Given this list of marker genes COPS8, DDB2, ACTL6A, CUL4A, NFRKB, PARP2, INO80B, RAD23B, PARP1, COPS4, COPS3, MCRS1 (microspherule protein 1), XPC, COPS7A, DDB1, RBX1, RPS27A, COPS6, COPS2, ACTB, UBA52, INO80C, COPS5, CUL4B, INO80D, RAD23A, GPS1, COPS7B (NCBI Gene Id 64708), INO80E, YY1, INO80, ACTR8, RUVBL1, UBB, CETN2, ACTR5, UBC (NCBI Gene Id 7316), TFPT, here is a description of the gene set: part of: Global Genome Nucleotide Excision Repair (GG-NER) Reactome Pathway: DNA Damage Recognition in GG-NER species: Homo sapiens In global genome nucleotide excision repair (GG-NER), the DNA damage is recognized by two protein complexes. The first complex consists of XPC, RAD23A or RAD23B, and CETN2. This complex probes the DNA helix and recognizes damage that disrupts normal Watson-Crick base pairing, which results in binding of the XPC:RAD23:CETN2 complex to the undamaged DNA strand. The second complex is a ubiquitin ligase UV-DDB that consists of DDB2, DDB1, CUL4A or CUL4B and RBX1. The UV-DDB complex is necessary for the recognition of UV-induced DNA damage and may contribute to the retention of the XPC:RAD23:CETN2 complex at the DNA damage site. The UV-DDB complex binds the damaged DNA strand.